The following is a description of a gene set: studied in species Homo sapiens Reactome Pathway: OTC variants cause OTC deficiency Ornithine transcarbamylase (OTC) is a mitochondrial enzyme essential to the urea cycle that catalyzes the transfer of a carbamoyl group from carbamoyl phosphate (CP) to ornithine to form citrulline, enabling detoxification of ammonia in the liver and small intestine.<br>The gene encoding OTC has 10 exons and produces a 354‑amino‑acid precursor, processed to a 322‑amino‑acid mature enzyme organized as a homotrimer containing three active sites. An N-terminal leader sequence (~34 aa) is required for mitochondrial targeting. Several motifs have been identified in OTC that contribute to ornithine and carbamoyl phosphate binding and catalysis; there is additionally an SMG motif (serine 267, methionine 268 and glycine 269) that is thought to undergo conformational changes upon substrate binding to cap the active site.<br>Mutations in the OTC gene give rise to OTC deficiency (OTCD; OMIM 311250), the most common of the urea cycle disorders. OTC deficiency may present neonatally or later in development depending on the severity of the underlying mutation, and like most disorders of the urea cycle, is characterized by hyperammonemia with resulting neurological consequences. part of: Diseases of the urea cycle, and this is the list of marker genes: OTC